The following is a description of a gene set: Genes up-regulated in B cell 7d vs 0d in young adults (18-50) after exposure to FluMist, time point 7D studied in species Homo sapiens Human Gene Set: NAKAYA_B_CELL_FLUMIST_AGE_18_50YO_7DY_UP from publication Nakaya HI, Wrammert J, Lee EK, Racioppi L, Marie-Kunze S, Haining WN, Means AR, Kasturi SP, Khan N, Li GM, McCausland M, Kanchan V, Kokko KE, Li S, Elbein R, Mehta AK, Aderem A, Subbarao K, Ahmed R, Pulendran B (PMID 21743478) Here we have used a systems biology approach to study innate and adaptive responses to vaccination against influenza in humans during three consecutive influenza seasons. We studied healthy adults vaccinated with trivalent inactivated influenza vaccine (TIV) or live attenuated influenza vaccine (LAIV). TIV induced higher antibody titers and more plasmablasts than LAIV did. In subjects vaccinated with TIV, early molecular signatures correlated with and could be used to accurately predict later antibody titers in two independent trials. Notably, expression of the kinase CaMKIV at day 3 was inversely correlated with later antibody titers. Vaccination of CaMKIV-deficient mice with TIV induced enhanced antigen-specific antibody titers, which demonstrated an unappreciated role for CaMKIV in the regulation of antibody responses. Thus, systems approaches can be used to predict immunogenicity and provide new mechanistic insights about vaccines., and this is the list of marker genes: ZBTB38, UXS1, SHMT2, WDR12, LRRC1, MARCHF7, NGDN, CACYBP, TADA3, KRT14, JUN, TUBGCP4, LARGE1, AKAP1, SDHAF1, PPP2R5E, SF3A3, CASP3, ELF2, PDE4DIP, GALNS, TOX4 (TOX high mobility group box family member 4), PIP5K1A, FRYL, CCT4, RAB9A, ADRM1, LETM1, TBC1D30, PCM1, GPR89A, TFIP11, DOCK2, SPTLC1, ANKRD36, ANKHD1, PIGG, CPSF6, ATM, HLA-DOA, C1orf56, TRAF5, INTS9, CSE1L, IDS, ANAPC15, PCDH9, UNC50, HECTD3, SKP1, FTSJ1, KHDRBS2, ATP6V0C, YPEL1 (NCBI Gene Id 94021), TUBB2A, SSPN, TOP3A, SPECC1L, SFXN3, TWF1 (twinfilin actin binding protein 1), CEMIP2, DNAJB1, SMCHD1, TTF1, AKAP17A, TP53TG1, FCF1, FKBP5, ZNF749, PPP2R1B, C1orf105, FAM120C, PTPN1, RPL37A, DDR1, NPY, MROH7, SEC23B, PPP1R11 (protein phosphatase 1 regulatory inhibitor subunit 11), CLCC1, SUGP1, FAF2, ITPA, RABEP2, ZBTB10, LZTR1, C1QTNF3, PHF20, WTAP, EIF5B, BCL10, INPP4A, COL4A3 (NCBI Gene Id 200750), ZNF155, ST13, GID4, FCRL2, TM7SF3, RGS20, ZMYM5, IGF2R, KLF9, GVINP1, ZNF208, CCDC88C, POLDIP3, ABRAXAS2, TRMT112, WEE1, TSPYL5, NUP160, NDUFS4, INTS7 (NCBI Gene Id 25896), AQR, MYL6B, COPS5, SRBD1, TLE1, UBE3B, CD22, SCAF4, CD300A, TARP, KIN, SIAH2, NFATC2IP, VAMP1, NF1, SP110, GART, MTRF1L, CNPPD1, LDAF1, DGKD, TMOD1, CKS2, APPBP2, ATP13A1, CBX1, RIDA, TOMM70, RPAP2, SERPINB8, ABHD10, ARHGAP1, YEATS2, FOXN3, FAM117A, STX6, PEX3, GTF2H1 (general transcription factor IIH subunit 1), FKBP14, THSD1, ILF3 (NCBI Gene Id 54783), RPP21, MAP4, RAP2A, CD2BP2 (CD2 cytoplasmic tail binding protein 2), ZNF318, IGHA1, TUBGCP3, MPHOSPH9, EIF2S1, AGL, TRAM2, OSBPL3, TCEAL1, RIPOR2 (NCBI Gene Id 9750), PARP2 (NCBI Gene Id 10038), GPR89B, CD24, IL16, PCMT1, LIG4, HUWE1, SLC30A4, RPL28, ZC3H14, TMSB4Y, IFT57, PJA1, NR2C1, SPTSSA, NAT9, CUL5, TRIM39, CTNND1 (catenin delta 1), TREML2, ETS1, BIN1, IGHG3, NKAPD1 (NCBI Gene Id 55216), ZBED2, MLF2, MTDH, RAP2B, SMIM8, DUSP12, EHBP1, ITK, TMEM41B, PPM1D (NCBI Gene Id 8493), MAST3, HRK, PRIM2, UROD, CLCN6, ADORA2A, GRK6, GFRA2, DSP, LIMK2, ANKHD1-EIF4EBP3, ABHD4, TRPC1, RALGDS, HYI, ANK3, CEACAM1, TUBB4A, EOLA1, NLK, ZNF484, MEX3C, MFNG, TRMT13, RSRP1, METTL2A, ERN1, TBC1D5, PER2, PDHX, NDST2, ERH (NCBI Gene Id 95660), AHCYL1, FIG4, UNG, KSR1, RBBP6, ORAI2, STK17A, TM2D1, ASMTL, NCOA3, SMPD1, ABHD2, CD200, ENPP4, ABCB1, MRTFA, MAP2K4, WDR59, PLPP1, EPM2A, NME6, RB1, MTMR1, CDC5L, MARCHF8, ZNF480, ADCY7, MECP2, ERG28, GARRE1, PRDX6, IL5, PKNOX1, CRLF3, LCMT1, CEP170, SNRPA, ANGEL2, CLCNKA, SLC25A36 (solute carrier family 25 member 36), BRCA2, ASTE1, MRM3 (NCBI Gene Id 55178), SMAD3, PLAGL1, PPP1R13B, CEP68, ENTPD1, COPS7B, BTAF1, RBM41, CSPP1, EOLA2, RASGRP3, SLC25A14, RHOBTB3, TXNRD1, ERP44, ZBTB25, IFT74, IGLV4-60, TCL6, PDCL3, ZBTB16, UBL3, MGST3, SKAP1, CEP290, GCDH, PTOV1, OSBPL10, SETD6 (SET domain containing 6, protein lysine methyltransferase), CCR7, ASF1A (anti-silencing function 1A histone chaperone), TTLL12, SH3GLB2, TWNK, TTC4, CCND3, PIK3C3, KLHDC10, CDC42SE1, CLCNKB, GTF3A, SLC25A11, TAFAZZIN, DNAH7, DECR1, SEC24A, RANGRF, TRGC2, DBT, TSTD2, OSGIN2, DXO, AIMP2, ST6GAL1, WDR77, IFRD1, CD226, DBP, TRIO, ZNF573, MRPS30, RBM15B, RUNX1, AP2B1, HAX1, AMACR, PNN, ZNF131, PIK3IP1, NT5E, CSNK2A2, PYGM, UEVLD (NCBI Gene Id 55293), MYCBP, INTS1, ZKSCAN1, WSB1, MLX, ALDH7A1, TMX4, TMSB15B, APEX1, FOXM1, ARL17A, AKR7A2, ARNT, CYB5A, NDUFC1 (NCBI Gene Id 4717), DCAF10, ZNF142, REEP5, YME1L1, ABCB4, IGHV4-31, H2AC17, DLG1, SAMM50, SH3YL1, RWDD3, DNAJB12 (NCBI Gene Id 54788), PTPN11, IGHD, MAGOH, RIOX2, PHF14, ARMC8, INVS, DLGAP4, GNAI3, MAPK13, RBFA (NCBI Gene Id 79863), GCOM1, CNTNAP2, ATMIN, HEMK1, ERLIN2, ITGB1BP1, NSUN5P1, LIPE, BMP2K, UBE2B, PSEN2, IGHM, CAND1, DDX11, CARS1, PDIA4, ARF6, SARM1, IRS2, RUVBL2, TBCC, PSMC3IP, ABCA1, IGHG1, SUMO3, ANAPC13, FLI1, RFK, MYOM1, RBL2, DTX4, DENND4B, GOLM1, PAIP2B, RGS1, CREBZF, POLM (DNA polymerase mu), PSMD13, SIGIRR, UFC1, ARL5A (ADP ribosylation factor like GTPase 5A), USP46, TNKS, PTPN22, BTG3, WIPF2, XRCC1, HERC4, ANKRD12, UBA6, TIMP3, RNGTT, DNAJB9, MLH3, STOM, EIF4G2, SLC11A2, RIC8A (NCBI Gene Id 60626), ZNF468, TAX1BP3, OGFOD2, GBX2, GPSM2, SLC35E2A, ARL17B, GALNT2, RAD51D, DCLRE1C, RRP1B, CDK2, PCF11, HACD2, POLR2M, C1orf50, FOXO4, BAG1, SPAST, LY75, ZXDB, EXOG (NCBI Gene Id 9941), PCNA, TPD52, METTL2B, MAVS, ZNF133, IL27RA, MMUT